Given this list of marker genes Tfap2a, Ctnnb1, Nkx2-1, Spry1, Fgf8, Bmp2, Fzd5, Frs2, Fgf1, Hipk2, Hoxa11, Ar, Hoxc11, Wnt2b, Wnt1, Six3, Fgf10, Six1, Robo2, Pou2f1, Dkk1 (NCBI Gene Id 13380), Sall1, Robo1, Fgfr1, Sox8 (SRY (sex determining region Y)-box 8), Wnt4, Fgfr4, Hoxd11, Hipk1, Wnt2, 2210016L21Rik, Wnt3, Fgf2, Mesp1, Sox9, Gata5, Bmp4, Gdnf, Fgf3, Sox2, Rbpj, here is a description of the gene set: A developmental process involving two tissues in which one tissue (the inducer) produces a signal that directs cell fate commitment of cells in the second tissue (the responder). Mouse Gene Set: GOBP_DEVELOPMENTAL_INDUCTION species: Mus musculus